The following is a description of a gene set: Hypoplasia of the radius Underdevelopment of the radius. studied in species Homo sapiens Human Gene Set: HP_HYPOPLASIA_OF_THE_RADIUS, and this is the list of marker genes: FGF10, ALG12, PALB2, ATR, NPR2, RECQL4 (RecQ like helicase 4), RBM10, SF3B4, RFWD3, FANCI, CHN1 (NCBI Gene Id 27011), FGFR3, COL2A1, SHOX, EIF4A3, IHH, APC, SALL4, ROR2, FANCB, ESCO2, TBX3, DHODH, RPL26, DONSON, FANCF, XRCC2, PRKAR1A, DVL1, TBX5, TRIP11, CCNQ, NIPBL, PDE4D, RBM8A, FGFR2, MAFB, AFF4, RAD51C, LRP4, SLX4, GDF5, WNT7A, IFT81, RPS19